Given this list of marker genes CD58, THAP11, SOCS3, CCND2, PHB1, DUSP2, CTSA, OPTN, TUBB4B, MNDA, CD1C, HCCS, TPI1, CAB39 (NCBI Gene Id 51719), AIM2, CUTA, KPNA2, ARHGAP25 (NCBI Gene Id 9938), IFI6, MDFIC, SLC25A4, BHLHE40, NRBP1, IFI30, TLE3 (TLE family member 3, transcriptional corepressor), COL4A3, COBLL1, SND1, IGKV3-20, JAM3, NCF4, M6PR, PAPSS1, SP140, TYMP, SLC35D2, GAPDH, SDHB, ATP1A1, DNAJC9, SMARCB1, ECHDC2, KCNN4, SLC7A7, PLP2, HSPA6, TMED3, AMPD2, USP48, CYCS, PTPN18, DOCK10, CD82, ZBTB32, KLF10, LMO4, CCT5, CKAP4, ACAT1, S100A10, DEPDC5, TM9SF2, PLEK, PDCD5, ZBTB38 (NCBI Gene Id 79779, zinc finger and BTB domain containing 38), LGALS1, CD27, CAPN2, PPP1R16B, RNF34, AHNAK, DAAM1, ZMIZ1, TBC1D9, HLA-B, DDAH2, RALGDS, SCRN1, SGPP1, TMEM14A, SACS (sacsin molecular chaperone), ANXA2, CTSC, SNHG20, MAP4K1, VOPP1, EGLN1, MVP, ACP5, PLAAT4, PYCARD, GGA1, CNP, TFDP1, ACTG1, GAB2, ATP5IF1, VIM, MRPL40, MCM5, FUT8, SINHCAF, GPM6A, CLDND1, GPR183, CD70 (NCBI Gene Id 970), SPAG7, CTSH, SAMSN1, MARCKS, WIPI1, LY96, ITGB1, ALDOA, ELOVL1, PBXIP1, S100A4, CBFA2T3, CD24, SNU13, TWF2, EHD3 (NCBI Gene Id 30845), ABCC4, ITGB7, PFKP, VAMP1, DNAJC7, CCNG1, CDV3, EVI2A, HSD17B10, CLUH, NANS, BHLHE41, PPA1, PRPF19, FABP5, PXDC1, CAPG, HTATIP2, EEF2, TRAPPC2L, DCPS, KCNG2, CSGALNACT1, RAB31, TNS3, IL10RA, PPIF, COTL1, ITM2C, ANXA2P2, TOR4A, XBP1, STX8, TRAF4, FH, RAD50, LDHB, ING1, TUBB, TRAM2, SEC61B, GAMT, RGS10, RORA, GRAP, ITGAM, MBIP, RAB4A, GNG11, ERO1A, GRN, GBA1LP, EIF2AK2, TRAF3, ATP5F1A, TFEC, ZBTB20, EHD1, SLC15A3, EEIG1, FCGR2A, COCH, ST3GAL5, TNFRSF1B, PLSCR3, AP3S1, LPXN, CRIP1, TPD52L2, TOR3A, DECR1, LDLRAP1, TMED1, CD1D, NQO2, here is a description of the gene set: Genes down-regulated in comparison of naive B cells versus memory IgM B cells. Immune cell-specific expression is one indication of the importance of a gene's role in the immune response. In order to identify such patterns, we set out to broadly profile gene expression in a variety of immune cells. species: Homo sapiens from publication Abbas AR, Baldwin D, Ma Y, Ouyang W, Gurney A, Martin F, Fong S, van Lookeren Campagne M, Godowski P, Williams PM, Chan AC, Clark HF (PMID 15789058) Human Gene Set: GSE22886_NAIVE_VS_IGM_MEMORY_BCELL_DN